Given this list of marker genes C5orf52, NPAS4, MIR7-3 (microRNA 7-3), MIR7-3HG, PEAK1, GARNL3, EXOC8, AGPS, ENC1, ATP10B, GAPDHP25, RPS29, MLLT3, LINC00431, SPDL1, RAD1, SH3RF2, ARHGAP32, HIKESHI, SRI, HMG20A, SPRTN, RNA5SP60, CETN3, RNU5A-1, MALAT1, TNFSF9, HMGCR, GPRC5D-AS1, CLPTM1, here is a description of the gene set: Genes containing one or more binding sites for (LMX1B) in their promoter regions (TSS -1000,+100 bp) as identified by GTRD version 20.06 ChIP-seq harmonization. from publication Yevshin I, Sharipov R, Kolmykov S, Kondrakhin Y, Kolpakov F (PMID 30445619) species: Homo sapiens Human Gene Set: LMX1B_TARGET_GENES